The following is a description of a gene set: species: Homo sapiens The series of events required to receive a sweet taste stimulus, convert it to a molecular signal, and recognize and characterize the signal. This is a neurological process. Human Gene Set: GOBP_SENSORY_PERCEPTION_OF_SWEET_TASTE, and this is the list of marker genes: ITPR3, TAS1R2, RGS21 (NCBI Gene Id 431704), REEP2, TAS1R3 (taste 1 receptor member 3), CALHM1, GNAT3